Given this list of marker genes CDH1, CHI3L1, BAX, MYC, IL6ST, E2F1, SOCS3, STAT3, MMP9, TP53, here is a description of the gene set: Human Gene Set: WP_MAMMARY_GLAND_DEVELOPMENT_INVOLUTION_STAGE_4_OF_4 Mammary gland development: involution - stage 4 of 4 species: Homo sapiens